The following is a description of a gene set: Human Gene Set: GSE20152_SPHK1_KO_VS_HTNFA_OVEREXPRESS_ANKLE_DN The study analyzes analyzes gene expression changes in the ankle joint in mouse TNFa overexpression models with or without sphingosine kinase 1 activity. SphK1 is a sphingolipid enzyme that converts sphingosine to bioactive sphingosine-1-phosphate (S1P). Recent data suggest a potential relationship between SphK1 and TNFα and have implicated SphK1/S1P in the development and progression of inflammation. Here we further study the relationship of TNFα and SphK1 using an in vivo model. Transgenic hTNFα mice, which develop a spontaneous arthritis (limited to paws) at 20 weeks, were crossed with SphK1 activity null mice (SphK1-/-) to study the development of inflammatory arthritis in the functional absence of SphK1. Results show that hTNF/SphK1-/- have significantly less severity and progression of arthritis and bone erosions as measured through micro-CT images. Additionally, less COX-2 protein, mTNFα transcript levels and fewer Th 17 cells were detected in the joints of hTNF/SphK1-/- compared to hTNF/SphK1+/+ mice. Microarray analysis of the ankle joint showed that hTNF/SphK1-/- mice have increased transcript levels of IL-6 and SOCS3 compared to hTNF/SphK1+/+ mice. Finally, fewer mature osteoclasts were detected in the ankle joints of hTNF/SphK1-/- mice compared to hTNF/SphK1+/+ mice. These data show that SphK1 plays a role in hTNFα induced inflammatory arthritis, potentially through a novel pathway involving IL-6 and SOCS3. studied in species Homo sapiens Genes down-regulated in ankle joints: SPHK1 versus wildtype over-expressing TNF. from publication Baker DA, Barth J, Chang R, Obeid LM, Gilkeson GS (PMID 20644167), and this is the list of marker genes: ORC4, FAM200C, TRMT61B (tRNA methyltransferase 61B), BAG2, RDX, ZNF22, ACAD8, DDX28, TMEM63A, STAM, SUPT20H, INTS5, NEIL3, POLR1B (RNA polymerase I subunit B), NHEJ1, RPL18, BMPR1A, CASP8AP2 (NCBI Gene Id 9994), C3AR1, PARP1, FIS1, CCNE1, XPO7, ZNF177 (zinc finger protein 177), LCE2B, PER2, CHRM5, ANP32B, RMI1, SSRP1, MSN, CHD8, TNPO3, NVL, HILPDA, TMX4, TP53, MRPL52, TARS2 (NCBI Gene Id 80222), ZNF665, ANXA9, ETHE1, CORO1A, NME6, RIOX1, TJP2, CBX5, NUDC, KAT7, CROCCP2 (NCBI Gene Id 84809), DCLRE1A, THAP11, GRK2, NEK9, RPS6KB1 (ribosomal protein S6 kinase B1), CNOT7, SS18L1, DDX11, PCYT2, SLC2A4, AGGF1, SMIM7 (small integral membrane protein 7), SOS1, DNAJC22, TRMU, ZBTB18, HIRA, TOP2A, XPO1, AATF, SOX3, RSBN1, APOBEC3C, PPP1CC, CAMK2N1, RPL26L1, ARHGAP25, GGA2, PIK3R3, TAF5, SINHCAF, RNF8 (NCBI Gene Id 9025), EI24, RUSC1, TOR1A, PPM1D, FOXRED2, FDXR, CYP2E1, CIT (citron rho-interacting serine/threonine kinase), VDAC1, PSMC3, SNAPC5, AARSD1, PTPN4, CLUH, CHST11, ZNF45, PACSIN2, EIF4EBP2, ZNF551 (NCBI Gene Id 90233), CENPJ, GLYR1, TRIM26, RLIG1, CSRP1, PTPRJ, GTF3A (NCBI Gene Id 2971), ACD, PGRMC2, DDX56, EFNA3, TMEM231, KIFBP, CNOT8, CCNA2, GRIN2C, HS1BP3, ADSS2, MTFR1, RASGRP2, SSX5, ZNF174, DTWD1, PRUNE1, ORC5, FBXW4, PDIA6, PPAT, MAML1, SLC35A1, DPP3, MGMT, NENF, ZBTB14, ARFIP1, YIPF1, MAGI1, PEX3, PAGR1 (NCBI Gene Id 79447), PATZ1, KANSL1L, TUBG1, ASB1 (NCBI Gene Id 51665), ABCC5, TCFL5, SYNE1, XRCC6, HPS6, CASP6, ZSCAN16, NUP205, RPL5, MIEF1, TBC1D31 (TBC1 domain family member 31), HSD17B4, PCYOX1L, TNRC6B, MRPS34, LRFN4, NPAS2, CEP350 (centrosomal protein 350), UBE2L3, BLMH, SENP3, CEACAM3, HPS1 (NCBI Gene Id 3257), MORC4, SNAPC4, ZNF33B, PHF20, FHL1, NSUN5, TMEM80, RANGRF, MID1IP1, LRFN3, REXO4, GIMAP6, UBB, HARS2, GTF2I, SESN1, TRMT1L, TUBA4A, NAGLU, H2AC14, TSR3 (NCBI Gene Id 64721), BMAL1, KHSRP, RUVBL1, ATXN7L3B, DNAJC16, TCF20, IMMT, ADORA3, ESYT1